Given this list of marker genes Msh2, Atad5, Ighd, Sh3kbp1, Inpp5d, Tbx21, Tfrc, Nod2, Sash3, Tnip2, Slc39a10, Mlh1, Kmt5c, Ighm, Il4, Cd81, Prlr, Ppp2r3c (NCBI Gene Id 80481), Gpr183, Peli1, Chrnb2, Nfatc2, Il3, Ifng, Spi1, Exosc6, Mmp14, Il13, Cd38, Il21, Il6, Btk, Tnfsf13b, Cd27, Shld3, Tirap, Stat5b, Irs2, Bad, Ada, Tcf3, Pcid2, Cd320, Il2rg, Nsd2, Pnp, Stat6, Pagr1a, Bcl2, Trp53bp1, Akirin2, Il7 (interleukin 7), Tnfrsf4, Cdkn1a, Il2 (interleukin 2), Ticam1, Shld1, Wnt3a, Ddrgk1, Mif, Kmt5b, Shld2, Cd40, Vav3, Mad2l2, Ptprc, Il10, Rif1, Tnfrsf13c, Syk, Card11, Atp11c, Nckap1l, Bmi1, Tlr4, Exosc3, Tlr9, Stat5a, Tnfsf4, Bcl6, Clcf1, Paxip1, Bst1, Xbp1, Il5, Hmces (NCBI Gene Id 97315), Cd28, Tnfsf13, Cd74, Ephb2, Tgfb1, Mef2c, Cd40lg, Pms2, here is a description of the gene set: Mouse Gene Set: GOBP_POSITIVE_REGULATION_OF_B_CELL_ACTIVATION Any process that activates or increases the frequency, rate or extent of B cell activation. species: Mus musculus